The following is a description of a gene set: species: Mus musculus The directed movement of substances that are gaseous in normal living conditions into, out of or within a cell, or between cells, by means of some agent such as a transporter or pore. Mouse Gene Set: GOBP_GAS_TRANSPORT, and this is the list of marker genes: Car14, Hba-x, Bpgm, Rhbg, Aqp1, Car4, Car12, Car2, Aqp5, Ngb, Hba-a1, Cygb, Rhcg, Hbb-bh1, Aqp4, Hbb-bh0, Hbb-y, Rhag, Hbb-bs, Aqp6, Mb